The following is a description of a gene set: Replication of the negative sense genomic RNA of the human respiratory syncytial virus (RSV) occurs through the positive sense intermediate, also known as antigenomic RNA. RNA synthesis is performed by the RNA-dependent RNA polymerase (RdRP) complex composed at a minimum of the L protein, which is the catalytic subunit of RdRP, and P protein. Protein M2-1 that acts as a processivity factor is described as a consitutive RdRP subunit by some and as an accessory RdRP subunit by other studies. Replication of both genomic and antigenomic RNA depends on encapsidation by protein N, which has regions that interact with both protein P and protein L. Encapsidation protects genomic and antigenomic RNA from degradation as these RNAs do not possess the 5' cap and the poly(A) tail. Replication occurs after primary transcription. Accumulation of the protein M2-2 is responsible for the shift of RNA synthesis from transcription to replication through a mechanism that has not been fully elucidated (For review, refer to Collins and Melero 2011, Battles and McLellan 2019). part of: Respiratory syncytial virus (RSV) genome replication, transcription and translation species: Homo sapiens Reactome Pathway: Respiratory syncytial virus genome replication, and this is the list of marker genes: M2-2, N, HSP90AB1, M2-1, Human respiratory syncytial virus A2, complete genome, Human respiratory syncytial virus A, HSP90AA1, L, P